Given this list of marker genes IGLV2-11, FCGR1A, FCGR2A, IGHV3-53, IGHV3-11, IGKV1-17, IGHV1-69, IGKV1-12, IGKV1-39, IGHG1, IGLV1-40, IGLV1-51, IGLV3-27, PLCG1, PIK3CA, IGLC3, PLPP4, IGHV1-2, PLD1, PLPP5, IGLV1-44, IGKV3-11, IGHV1-46, IGLV3-25, IGHV3-23, IGLV2-23, IGHV2-70, PLCG2, SYK, IGLV1-47, IGHV2-5, IGLV2-14, IGKV1D-12, IGKV1-33, IGHV3-7, IGHV4-39, IGKV3D-20, PLA2G6, IGLV6-57, IGKV2D-40, IGKV1D-16, IGKV2-28, IGKV1-5, PLD3, CD247, IGHG4 (immunoglobulin heavy constant gamma 4 (G4m marker)), IGLV3-1 (immunoglobulin lambda variable 3-1), IGKV4-1, IGKV2D-28, PIK3R1, IGKV3-15, IGLV3-21, IGHV4-34, ITPR3, IGKV1D-39, IGLC2, PIK3R2, IGHV3-33, PLD2, PRKCD, IGKV2D-30, IGKV1D-33, PLD4, IGLV7-43, IGHG2, ITPR1, PRKCE, IGHV3-30, IGKV3-20, PIK3CB, IGHV3-13, IGHV3-48, IGLV2-8, IGHV4-59, FCGR3A (Fc gamma receptor IIIa), CD3G, IGKV1-16, ITPR2, IGLV3-19, AHCYL1, IGKV2-30, IGKV5-2, here is a description of the gene set: studied in species Homo sapiens Role of phospholipids in phagocytosis Human Gene Set: REACTOME_ROLE_OF_PHOSPHOLIPIDS_IN_PHAGOCYTOSIS